The following is a description of a gene set: Mouse Gene Set: GOMF_PROLACTIN_RECEPTOR_BINDING studied in species Mus musculus Binding to a prolactin receptor., and this is the list of marker genes: Prl2c2, Prl2c3, Prl7c1, Prl8a2, Prl7b1, Prl8a6, Gh, Hsd17b7, Prl2c5, Prl2c1, Prl5a1 (prolactin family 5, subfamily a, member 1), Prl3a1, Prl3d3, Prl7a1, Prl3c1, Prl2a1, Prl3d2, Prl2b1, Prl8a8, Prl4a1, Prl6a1, Prl, Prl7a2, Prl8a9, Prl3b1, Prl7d1, Prl8a1, Prl3d1